Given this list of marker genes BCKDHB, DLD, DBT, BCKDHA, here is a description of the gene set: part of: Maple Syrup Urine Disease Loss-of-function mutations in DBT disrupt the integrity of the E2 subunit of BCKDH, resulting in MSUD2. studied in species Homo sapiens Reactome Pathway: Loss-of-function mutations in DBT cause MSUD2